The following is a description of a gene set: from publication Chen Y, Wang X (PMID 31504780) Genes predicted to be targets of miRBase v22 microRNA mmu_miR_7086_5p in miRDB v6.0 with MirTarget v4 prediction scores > 80 (high confidence targets). species: Mus musculus Mouse Gene Set: MIR_7086_5P, and this is the list of marker genes: Msl3, Foxk1, Peak1, Ppargc1a, Neurl1a, Atp1b2, Rcan2, Srcin1, Dpys, Erc1, Fbln5, Man1a, Dgkk, Mpp7, Tagln3, Mapk8, Fcer2a, Gng4, Ubn2, Ilrun, Slc6a17, Sarm1, Colec10, Mpp2, Phox2b, Fmo1, Itsn1, 0610030E20Rik, Hdgf, Skint9, Pudp, Ark2c, Ikzf4, Pomk, Mlxip, Hipk1, Ormdl2, Nkain2, Stk32b, Psmd10, Tor1aip2, Ctr9, Slamf6, Ift22, Loxl1, Mlph, Sbk3, Zfp91, Negr1, Folr2, Prr36, Tspan18, Ugt3a2, Sox6, Katnbl1, Ifnar2, Inka2, Uhmk1, Olr1, Fsd1l (NCBI Gene Id 633268), Siglece, Trappc3, Ehd1, Sec22c, Mtcl2, Cd47, Usp17la, Gm5878, Sbno1, Trim67, Psd2, Slc35d1, Hmg20a (high mobility group 20A), Diras1 (DIRAS family, GTP-binding RAS-like 1), Tram1, Sfxn3, Slc7a15 (NCBI Gene Id 69827), Paip1, Dlg1, Tcta, Tyw1, Arhgap15, Zdhhc9, Phactr2, Tbc1d20, Ptprb, Irf6, Lysmd1, Pfpl, Iqsec2, Crtac1, Tmprss11c, Mical2